Given this list of marker genes CLN3, LTB4R2, FER, MIXL1, KANK2, THBS1, APELA, TESK1 (testis associated actin remodelling kinase 1), EDN1, AKAP12, CORO1C, MARVELD3, CALR, ITGB4, GDNF, FGF10, RET, MTOR, PTEN, DUSP10, ACVR1B, KITLG, MAPRE2, TAC1, SMAD4, IQGAP1, GJA1, DOCK1, CD63, PDLIM1, SEMA6A, SEMA5B, SEMA4A, SMO, SRC, EPB41L4B, ITGB7, NODAL, MMP9, ITGB1BP1, FAM114A1, CTSH, ACVR1C, NCKAP1, RAB25, APPL2, MIR379, HIF1A, ENG, PLCG1, CCN3, FGF8 (fibroblast growth factor 8), SEMA3A, GPC3, RAB11A, BMP7, KANK1, PITX2, FGF7, PTK2, RIC8A, BMP4, KRT2, TACR1, MSTN (NCBI Gene Id 2660), AMOT, PKN3, MIR16-1, SYDE1, EFNB1, MIR145, ERBB4, PTPRG, GBX2, AQP1, VIL1, HAS1, MIR19B1, NANOS1, ITGB3, DMTN, DOCK5, ENPP2, MMP2, FGF19, RREB1, ILK, FGF2 (fibroblast growth factor 2), CLASP2, CDH2, PHACTR4, MTA2, NHERF1, IRS2, PTPRR, CFL1, KRT16, ACVR1, CRB2, ITGB1, TWIST1, TGFB1, OCLN, NRTN, CAP1, PTPN11, SEMA3D, ITGA4, MIR15B, ARHGEF7, SASH1, YTHDF3, CER1, SEMA4F, GDF6, SEMA5A, HBEGF, SRGAP2, FN1, TGFB2, PIP5K1A, SEMA4C, PKN1, EPPK1, C1QBP (NCBI Gene Id 708), HDAC6, HTR2B, CENPV, SEMA4D, MIR222, BMPR2, SNAI2, PLEC, NRP2, CDC42, TACSTD2, SEMA6B, EDN3, ADIPOR1, PAFAH1B1, RADIL, WNT5A, DDR2, ARHGAP4, SEMA4G, ROCK1, PFN1, SDC4, SEMA3F, SEMA3E, TBX1, FUT8, WDPCP (WD repeat containing planar cell polarity effector), SNAI1, LAMA5, ARF6, ITGA2, ARSB, TGFBR1, AKT1, RAC1, SEMA7A, ZEB2 (NCBI Gene Id 9839), SEMA6C, ITGA3, MESP1 (mesoderm posterior bHLH transcription factor 1), LRP5, PAK1, PTPN23, AGO2, FOLR1, INSL3, LRG1, MIR130A, SEMA6D, MACIR, SGPL1, RTN4, WASF2, CAPN7, NRP1, MIR19A, ACTA2, SMAD3, DAAM2, SEMA4B, SMURF2, HAS2, JUN, MCC, TMEM201, APPL1, PHOX2B, PPARD, FERMT1, GNA13, GLIPR2, TIMP1, KIT, ANLN, FAT2, ZFAND5, HAND2, ARID5B, RFFL, SEMA3G, SOX8, LAMTOR2, ISL1, CORO1A, CLASP1, PML, SEMA3B, PROX1, VEGFA, SHH, PRR5L, AMOTL1, EVL, AMOTL2, TNS1, FBN2, TPBG, IQSEC1, PFN2, PPM1F, OVOL2, EDNRB, SOX10 (NCBI Gene Id 8223), ARHGAP5, CD248, MAP4K4, ACVR2B, CYGB, SOX9, BRAF, DAB2IP, MEGF8, SOX17, EDNRA, EPB41L5, ARHGDIB, GNA12, MACF1, RCC2, PLCG2, IL4, HYAL2, ADAM9 (NCBI Gene Id 8754), BAG4, TGFBR2, IFNG, MIR221, SEMA3C, PKN2, SMAD2, PRKCE, here is a description of the gene set: Human Gene Set: GOBP_AMEBOIDAL_TYPE_CELL_MIGRATION species: Homo sapiens Cell migration that is accomplished by extension and retraction of a pseudopodium.